Given this list of marker genes Apc, Nudt1, Gast, Tff1, Tpx2, Tes, Sirt2, Pten, Pax6, Lzts1, Tgfb1, Nfe2l2, Smad4, Men1, Hras, here is a description of the gene set: species: Mus musculus from publication Motenko H, Neuhauser SB, O'Keefe M, Richardson JE (PMID 26092688) Mouse genes annotated to increased stomach tumor incidence (MP:0010301) retrieved from the Mouse Genome Informatics database via MouseMine Mouse Gene Set: MP_INCREASED_STOMACH_TUMOR_INCIDENCE